The following is a description of a gene set: Binds to and increases the activity of a peptidase that is involved in the apoptotic process. species: Mus musculus Mouse Gene Set: GOMF_PEPTIDASE_ACTIVATOR_ACTIVITY_INVOLVED_IN_APOPTOTIC_PROCESS, and this is the list of marker genes: Rack1, Ngf, Tnfrsf10b, Nkx3-1 (NCBI Gene Id 18095), Bcl10, Atp2a3, Ctsh, Pycard, Bad, Apaf1, Casp8ap2, Mapk9, Rps27l, Casp8, Ctsc